The following is a description of a gene set: studied in species Homo sapiens Human Gene Set: GOBP_ADENOSINE_TO_INOSINE_EDITING The conversion of an adenosine residue to inosine in an RNA molecule by deamination., and this is the list of marker genes: ADARB1, ADAT2, ADARB2 (NCBI Gene Id 55523), ADAR (adenosine deaminase RNA specific), ADAD1, ADAD2